The following is a description of a gene set: The bidirectional movement of large protein complexes along microtubules within a cilium, mediated by motor proteins. species: Homo sapiens Human Gene Set: GOBP_INTRACILIARY_TRANSPORT, and this is the list of marker genes: ARL3, IFT74, KIF3B, LCA5, DAW1, TTC21B, IFT81, IFT22, DYNC2I2, INTU, PCM1, DYNLL1, IFT70A, IFT46, SSX2IP, IFT122, BBS12, RPGR, SSNA1, WDR35, IFT27, IFT20, IFT70B (intraflagellar transport 70B), IFT52, IFT57, TUB, RABL2B, IFT25, IFT88, CCDC38, IFT56, TRAF3IP1, DYNC2I1, FUZ, CEP131, TTC21A, IFT172, DYNLT2B, DYNC2H1, CLUAP1, CILK1, IFT43, WDR19, DYNC2LI1, IFT80, WDPCP, LCA5L, NME7, MAK, IFT140